The following is a description of a gene set: species: Mus musculus Mouse Gene Set: GOBP_IMMUNE_RESPONSE_REGULATING_SIGNALING_PATHWAY The cascade of processes by which a signal interacts with a receptor, causing a change in the level or activity of a second messenger or other downstream target, and ultimately leading to the activation, perpetuation, or inhibition of an immune response., and this is the list of marker genes: Naglu, Eif2b5, Bcl2a1d, Irak3, Ankrd17, Sarm1, Nfam1, Aars2, Tlr5, Klrc2, Peli1, Btnl10, Cmtm3, Lpxn (leupaxin), Ffar2, Pik3r1, Cd14, Mbl2 (mannose-binding lectin (protein C) 2), Nlrp1b, Ddx60, Rps6ka3, Cd8a, Tlr7, Sirt2 (NCBI Gene Id 80489), Dusp22, Spsb3, Trim30a, Cd300lb, Sla2, Slc15a2, Zdhhc5, Clec12b, Gpr33, Psen2, Plcg1, Oas1a, Mavs, Rsad2, Becn1, Tmigd3 (transmembrane and immunoglobulin domain containing 3), Blk, Pigr, Trim15, Skint3, Traf3ip3 (TRAF3 interacting protein 3), Xiap, Eif2b1, Tlr2, Ptpn6, Rnf125, Irf1, Lilrb4a, Skap1, Oas1g, Laptm5, Skint1, Pik3ap1, Cacnb3, D1Pas1, Mapkapk2, Phb2, Braf (NCBI Gene Id 97330), Trav7-2, Ncr3-ps, F2rl1, Zdhhc1, Src, Oscar, Lgals3, Tnip3 (TNFAIP3 interacting protein 3), Btnl2, Ipo5 (NCBI Gene Id 97586), Lilra5, Pycard, Nmi, Lats2, Fer, Lat, Abhd17a, Plcl2, Ceacam1, Sh2d1b1, Fpr-rs6, Alpk1, Tasl, Rab7b (RAB7B, member RAS oncogene family), Rigi, Clec2i, Mefv, Lrch4, Phpt1, Itpripl1, Znrf4, Cd28, Nek7, Nod2, Cyld, Prkd1 (protein kinase D1), Klri1, Prkd2, Ifng, Nlrp6, Fpr2, Tespa1, Fpr3, Rftn1 (raftlin lipid raft linker 1), Ly96, Eif2b4, Dusp3, Pum1, Aurkb (aurora kinase B), Tlr12, Ermap, Igtp, Clec4e, Syk, Rnf170 (ring finger protein 170), Btrc, Ifi207, Prkdc, Irf7, Nr1h4, Fyb1 (NCBI Gene Id 320185), Tnfaip3, Rabgef1, Klrd1, Inava, Peli3, Sec14l1, Lck, Acod1, Eif2b2 (NCBI Gene Id 97826), Havcr2, Trim31, Cd300ld, Itch, Hras, Hspa8, Rtn4, Btnl4, Tnfrsf21, S100a14, Itgam, Eif2ak2, Lilra6, Tspan6, Rap1a, Ddx3x, Skint5, Cd36, Psen1, Prkce, Ighm, Pirb, Trim32, Tlr6 (toll-like receptor 6), Pvrig, Tlr11, Smpdl3b, Hspa1b, Skint2, Stoml2, Gfi1, Thy1, Skint8, Il20rb, Tarbp2, Fcgr3, Kcnn4 (NCBI Gene Id 16534), Pum2, Sh2d1a, Cd22, Mark4, Clec4d, Pten, Skint9, Dhx58, Ms4a1, Bax, Eif2b3, Otud4, Cr2, Mog, Nfkbil1, Arf6, Skint4, Tlr13, Clec4n, Zc3hav1, Nectin2, Tlr8, Cacnb4, Cd160, Trex1, Scimp, Ppt1, Skint6, Abl1, Irak2, Irf2, Cav1, Cactin, Ufd1, Ptgs2os, Ltf, Myd88, Ticam2, Rnf144a, Rnf115, Tirap (toll-interleukin 1 receptor (TIR) domain-containing adaptor protein), Klrc1, Wdfy1, Tab1, Fpr1, Cd276, Irak1, Tlr4, Btn2a2, Ptprj, Gpr108, Ogt, Pdpk1, Map3k7, Rbck1, Fpr-rs7, Pira12, Blnk, Sppl3, Ighe, Klrc3, Ptprs, Colec12, Plekha1, Lbp, Bcl2, Rnf135, Cd81, Appl2, Trim25, Ccr7, Ubr2, Prkch, Lyn, Cd86, Bag6, Lyplal1, Traf3, Bcl10, Carmil2, Gcsam, Pram1, Btk, Sqstm1, Fyb2, Otulin, Nlrp3, Gramd4, Txk, Zfp683, Plscr1, Fcrl5, Slc39a10, Tnip2, Rapgef1, Myo1g, Nras, Letmd1 (LETM1 domain containing 1), Riok3, Rnf34, Chuk, Stap1, Gbp2, Lsm14a, Oas1f, Cd300ld4, Klri2 (killer cell lectin-like receptor family I member 2), Casp4, Cd79b, Phb1, Cd2ap, Ifi214, Nck1, Fcgr1, Card11, Rela, Fcgr4, Vtcn1, Gata3, Hcfc2, Itk, Bpifb1, Vav3, Nlrx1, Cd300ld2, Lime1, C3ar1, Tkfc, S100a9, Cd274, Mef2c, Tifa, Kit, Clec7a (NCBI Gene Id 56644), Kir3dl1, Fcmr, Fpr-rs3, Btla, Blvra, Sting1, Ncr1, Gp6, Khdrbs1, Fcer1g, Nagk, Irgm2, Cblb, Mfhas1, Ppp6c, Aim2, Ctsh, Lrrc19, Lair1, Appl1, Parp1, Fosl2, Zdhhc12, Arrb2, Slc19a1, Hspd1, Tril (NCBI Gene Id 66873), Cd47, Vav2, Pde4d, A1bg, Pawr, Usp12, Irf4, Lgr4, Fyn, Unc93b1, Ifi203-ps, Csk, Nos2, Brcc3, Slc15a4, Wnk1, Trim11, Ap3b1, Esr1, Tyro3, Trem2, Gm15441, Dennd1b, Zdhhc9, Kcnj8, Tifab, Usp46, Csnk1a1, Rc3h1, Ticam1, Prkcb (NCBI Gene Id 319718), Epg5, Lat2, Crkl, Pira2, Tbk1, Brcc3dc, Nfkbid, Usp50, Klrk1, Ifi35, Tnf, Smpdl3a, Ikbkg, Lilrb4b, Nfkbia, Tnip1, Ezr, Gdi1, Irf3, Nr1d1, Fosl1, Ubqln1, Pira13, Btnl12, Pde4b, Ifi203, Zdhhc18, Nfatc2, Nr1h3, Nploc4, Oas1h, Ptpn22, Sos1, Fcer1a, Nr4a3, Zdhhc3, Erbin, Hmgb1, Prnp (NCBI Gene Id 98923), Dgkz, Plscr2, Btnl9, Irgm1, Rab29, Gm12250, Pcbp2, Ifi206, Gbp5, S100a8, Tmem126a, Cd300a, Plcg2, Shb, Ifi208, Usp9x, Zc3h12a, Kir3dl2, Cyba, Fcnb, Themis, Btnl6, Malt1, Pja2, Tlr3, Cd247, C5ar1, Stmp1, Cmklr1, Btn1a1, Themis3, Slc46a2, Oasl1, Gps2, Bmx, Traf6, Ube2n, Nfkb1, Akt1, App, Gkn2, Elf1, Znrf1, Ptprc, C3, C1qbp, Ripk2, Dab2ip, Tax1bp1, C5ar2, Cd79a, Mndal, Vav1, Clpb, Bcar1, Washc4, Rab11fip2 (RAB11 family interacting protein 2 (class I)), Mapkapk3, Reg3g, Ccdc134, Mapk8, Oas1d (2'-5' oligoadenylate synthetase 1D), Gpld1, Slc39a6, Dhx33, Flot1 (NCBI Gene Id 14251), Lrrc14, Gpatch3, Skint10, Nlrc3 (NCBI Gene Id 268857), Trim3, Lax1, Foxp1, Casp1, Lrrfip2, Cd3e, Btnl1, P2rx7, Zap70, Elp6, Skint11, Banf1, Ninj1, Icosl, Ifi213, Cd40, Zcchc3, Ada, Ifih1, Nfkbiz, Cd19, Fbxl2, Cptp, Fcho1, Tec, Grb2, Oas1c, Lacc1, Themis2, Lats1, Cd226, Ptpn2, Usp17le, Tlr9, Fcna, Ctla4, Treml4, Ecsit, Nod1, Ywhae, Lcp2, Igsf1, Cd8b1, Ubash3a, Atat1, Cd300lf, Rc3h2, Ifi209, Tarm1, Kcnk13, Cgas (NCBI Gene Id 214763), Lamp2, Stk11, Oas1e, Slc15a3, Oas1b, Skint7, Sh2b2, Foxp3, Tlr1, Klhl6, Usp15, Oas3, Trat1, Rps3, Mapk1, Tyrobp (TYRO protein tyrosine kinase binding protein), Nlrp1a, Ppp2ca, Cd38, Klre1, H2-M3, Nop53, Fpr-rs4, Cd300ld3, Fcer2a, Nckap1l, Lipa, Rnf31